Given this list of marker genes KIF23, LPIN2, RMRP, ZNF699, RPS19, here is a description of the gene set: Congenital hypoplastic anemia Human Gene Set: HP_CONGENITAL_HYPOPLASTIC_ANEMIA species: Homo sapiens A type of hypoplastic anemia with congenital onset.